Given this list of marker genes Rilpl1, Pmepa1, Ms4a6c, Flnb, Ms4a4b, Tmsb10, Akr1a1, Calhm6, Cd164, Nr4a3, Ms4a6b, Atp6v1d, Rnf31, H2-T22, Tor1aip1, Laptm4a, Calm1, AA467197, Eif2ak2, S100a6, Trim30d, Ankib1, Oasl2, Lamp2, Irgm2, Ehd4, Pkib, Zbp1, Ddx60, Serinc3, Sap30, Ifi213, Trim26, Lgals3bp, Stxbp3, Ifit3, Tdrd7 (NCBI Gene Id 230131), Itm2b, Ube2d3, Cmtm6, B4galt5, Nmi, Marchf5, Dnase1l3, Mx1, Mpeg1, Tapbpl, Bcl2l11, Car13, Rigi, Phf11a (NCBI Gene Id 71191), Cd86, Ube2l6 (NCBI Gene Id 67250), Casp1, Cxcl10, Ppa1, Dck, Trim30a, Usp18, Tmem106a, Xrn1, Stat2, Esyt1, Serpina3g, Cxcl9, Hmox2, Dusp5, Kpna3, Ccnd2 (NCBI Gene Id 97325), Actr2, Cflar (CASP8 and FADD-like apoptosis regulator), Macroh2a1, Ly6e, Ifit3b, Bbx, Asb13, Ywhah, Rnf213, Irgm1, Oas3, N4bp1, Ildr1, Dync1h1, Ifi211, Vps54, Parp11, Dbnl, Fbxw11, Ccrl2, Oas2, Zup1, Nono (non-POU-domain-containing, octamer binding protein), Snx2 (sorting nexin 2), Naa20, Mbd2 (NCBI Gene Id 17191), Phf11c, Zfp800, Anxa5, Arf4, Clic4, Ass1, Larp1, Marcksl1, Anxa2, Trim34a, Ifitm3, Plac8, Arhgap8, Chmp4b, Gbp5, Tspo, Parp10, Ptk2b, Lima1, Parp12, Mitd1, Npc2, Tnfsf10, Ogfr, Cers6, Trim14, Csrp1, Adar, Tent5a, Bst2, Clic1, Ifih1, Sdc3, Phf11b, Iigp1, Leprotl1, Ppp3ca, Parp14 (poly (ADP-ribose) polymerase family, member 14), Rab7, Prpf38b, Atp8a1, Igtp (NCBI Gene Id 16145), Ly86, Oas1a, Themis2, Cacybp, Tmbim6, Oasl1, Tap1, Ogfrl1, Cmpk2, Mxd1, Tmcc3, 9930111J21Rik2, Plekhn1, Ifit1, Cd52, Keap1, Mov10, Znfx1, Plaat3, Klrk1, Ifi206, Slc25a22 (solute carrier family 25 (mitochondrial carrier, glutamate), member 22), Slfn9, Ccdc6, Svbp, Slamf7, Fndc3a, Rab8b, Ifi205 (NCBI Gene Id 226695), Glipr2, Ndrg1, Ctss, Smchd1, Rnf19b, Cyp27a1, Arid5a (AT-rich interaction domain 5A), Uba7, Trim56, Trafd1, Tcof1, Txn1, Aida (NCBI Gene Id 72487), Dcp2, Gbp7, Cd47, Zc3hav1, Jaml, Dpy19l1, Capza2 (capping actin protein of muscle Z-line subunit alpha 2), Prkx, H2-T23, Ilrun, Myadm, Dennd1b, Apod, Gnai2, Plin2, Rsad2, Cptp, Ifi214, Rasa4, Dnajc7, Samd9l, Sppl2a, Ilk, Nampt, Ifi203, Tomm70a, Tcf4, Mndal, Tmem184b, Psme2b, Fam241a, Ifi27, Il15ra, Ms4a4c, Herc6, Tpm4, Selenot, Fgl2, Slfn2, Samhd1, Psmb8, Cpne3, Nt5c3, Selenow, Irf9, Ly6a, Ppm1k, Setdb2, Slc2a6, Coro2a (NCBI Gene Id 320131), Ifi209, Zcchc2 (zinc finger, CCHC domain containing 2), Sp100, Gbp9, Ifi208, Grina, Rbl1, Tor3a, Il15, Gramd2b (NCBI Gene Id 74540), Pdia3, Agrn, Gbp4, Casp4, Ccr7, Isg20, Psme1, Irf2, Irf7, Dpp4, Ifi27l2a, Gbp3, Abtb2, Ifit1bl1, Slfn5, Mycbp2, Sass6, Daxx, Msn, S100a11, Atp1b3, Baz1a, Psmb9 (proteasome (prosome, macropain) subunit, beta type 9 (large multifunctional peptidase 2)), Taldo1, Anxa4, Psmb10, Etnk1, Cnp, Ctsc, Rnf114, Pnp, Ifit2, Ptms, Sp110, Psme2, Isg15, Otud5, Il10ra, Tapbp, Phip, Prkcd, Ifi44, Dtx3l, Ccdc86, Fbrsl1, Isoc1, Trim12c, Ifi207, Rap1b, Tmem219, Shisa5, Ifi35, Cd40, Dipk1a, Tbc1d32, Dek, Sp140, Tap2, Ascc3, Fscn1, Usp25, Rtp4, Morc3, Xrn2, Stx3, Zc3h7a, Jpt1, Clec2d, Acadl, Nup88, Rpain, Nlrc5, Dse, Trim25, Phf11d, Dhx58, Nsd3, AI837181, Cdkn1a, Ly6c2, Bri3, Arpc5, Ifi47, Slfn8, Fbxw17, BC005537, Brd2, Inpp5b, Anxa7, Parp9, Tor1aip2, Dnaja2, Slfn1, Pnpla2, Hpcal1, Ifi204, Anxa1, Xaf1, Stat1, Gbp2, Lgals9, Map2k1, Aff1, Grn, Pml, Helz2, Rbms1, Pttg1, Trim12a, here is a description of the gene set: Genes positively differentially expressed in cell type: MigDC (migratory dendritic cell) upon treatment with cytokine: IFN-α1 in mouse lymph nodes in vivo. Mouse Gene Set: CUI_MIGDC_IFNA1_RESPONSE_UP from publication Cui A, Huang T, Li S, Ma A, Pérez JL, Sander C, Keskin DB, Wu CJ, Fraenkel E, Hacohen N (PMID 38057668) Cytokines mediate cell-cell communication in the immune system and represent important therapeutic targets. A myriad of studies have highlighted their central role in immune function, yet we lack a global view of the cellular responses of each immune cell type to each cytokine. To address this gap, the authors created the Immune Dictionary, a compendium of single-cell transcriptomic profiles of more than 17 immune cell types in response to each of 86 cytokines (>1,400 cytokine-cell type combinations) in mouse lymph nodes in vivo. A cytokine-centric view of the dictionary revealed that most cytokines induce highly cell-type-specific responses. For example, the inflammatory cytokine interleukin-1β induces distinct gene programmes in almost every cell type. A cell-type-centric view of the dictionary identified more than 66 cytokine-driven cellular polarization states across immune cell types, including previously uncharacterized states such as an interleukin-18-induced polyfunctional natural killer cell state. studied in species Mus musculus